Given this list of marker genes MYL6B, CSRP2, FASN, NUAK1, AIPL1, NECTIN3, ERAL1, GNL3L, TMPRSS3, ABCB8 (NCBI Gene Id 11194, ATP binding cassette subfamily B member 8), SEPTIN6, ELOVL4, PCNA, HIVEP3, HK3, P2RY10, APOBEC3B, MYG1, SINHCAF, CYLD, C3orf52, DNAJC3, MKLN1, SFXN1, POLD3, TRAC, RPA1, NFKBIB (NCBI Gene Id 4793), PECR, PRRC1 (proline rich coiled-coil 1), QSER1, TMEM156, NAPG, GOLT1B, NFYC, EVC, PSMB9, CENPU, NPDC1, DMC1, GBP1, EPOR, RBL1, ARHGEF18, DCLRE1A, LAIR2, PGGHG, IL26, MAL, FOXM1, PPP3CC, CCND3 (NCBI Gene Id 896), CSE1L, MYH10, SPTSSA, RALY, CMAHP, MAMLD1, GSK3B, ZWILCH, NCAPG2, KIF1B, ETS1, N4BP2L1, RAP1B, GNL1, NF1, TRIM58, SLC17A6, IFNA21, EIF3I, POLR2I, TREX1, PAICS, CDS2, MIS18A, IL10, RFC3, GZMB, TDP1, CDC25A, KIR2DL4, CD28, KNTC1, MTMR1 (myotubularin related protein 1), STEAP1, AK4, IDH3A, EXOSC9 (NCBI Gene Id 5393), TPX2, ABCA8, SCTR, SLC5A6, PDCD11, RAMP1, TAF5, MAP3K8, COL5A3, PDK3, SPSB1, SDC4, TNFRSF4, KLHL25, ANKRD11, ARMC6, LAG3, CLN6, GINS4, MORC4, KIF20B, ENTPD1, PPP1R7, SYNE3, GRM2 (glutamate metabotropic receptor 2), NCKIPSD, LMAN1, NDUFV2, APLP1, SIDT1, SQOR, GGA2, AGAP2, GOLGA8A, PELI1, TAP2, BIRC5 (NCBI Gene Id 332), KLF8, SOCS2, SNRNP25, HP1BP3, SRRM1, SECTM1, GMEB1, PPP6R2 (NCBI Gene Id 9701), MAPK8, RSRC1, IRF9, TXNL1, GCH1, BLM, GPN2, SPDEF, PPP1R2, PLK1 (NCBI Gene Id 5347), MRE11, IL2RG, LMNB1, AGK, TOMM40, PCDH12, POLR2D, RBM19, MYOM2, PCDH11Y, PDE4C, PYHIN1, INVS, ABLIM1, KDELR2, PA2G4, CBS, OPTN, ARF1, CTDSPL, EOLA2, SP140, SPAG5, PMAIP1, PIM2, UBE2K (NCBI Gene Id 84819), GGH, MSH2, HTRA2, SH2D1A, TM9SF4 (NCBI Gene Id 9777), MID1IP1, TIMELESS, METRN, ESF1, ARMCX2, SH2D3C, CLEC2D, CHST11, IL22, CFLAR, AURKA, TOP3B, FKBP5, PRDX3, PPM1G, ZEB1, MCUR1, TRAP1, CD79B, FERRY3, HLA-G, SERINC2, IRF4, here is a description of the gene set: from publication Jeffrey KL, Brummer T, Rolph MS, Liu SM, Callejas NA, Grumont RJ, Gillieron C, Mackay F, Grey S, Camps M, Rommel C, Gerondakis SD, Mackay CR (PMID 16474395) species: Homo sapiens Genes down-regulated in comparison of mast cells versus Th1 cells. Human Gene Set: GSE3982_MAST_CELL_VS_TH1_DN In the present study we used Affymetrix oligonucleotide microarrays to produce gene transcription profiles for the major leukocyte types in humans. This comprehensive dataset enabled us to not only establish which genes were expressed in each leukocyte type, but also which genes were expressed in each subset after activation. The used of a comprehensive dataset of gene profiles from all the major human leukocyte subsets enabled a novel and powerful means for identification of genes associated with single leukocyte subsets, or different immune paradigms.